Given this list of marker genes ATP2C1, CEBPB, EZR, AKAP5, GPD1L, TULP1, FLOT1, F2R, HAMP, APLN, P2RY2, GREM1, F2RL3, CARTPT, VAMP2, ATP13A2, CA2, HYAL2, ABCG1, SGK2, PTPRJ, TMED10, APOE, MPC2, IL1A, MIR223, TBC1D20, KCNB1, APELA, PDGFRB, APOA5, PLCG1, RUFY4, CASK, CDH3, PSEN1, VPS28, SCN5A, OSBPL8, CDK5, P2RY12, MS4A1, ZFAND1, VMP1, GAB2 (NCBI Gene Id 9846), MAP2, CXCL9, P2RX4, PCNT, ATP1B1, TRIM46, ITGAM, LRAT, RAB2B, CCR7, GABBR1, PLA2G10, ACTN2, LRRC52, STX18, KLRC2, STIM1, RAN, CTSS, P2RX7, KMO (kynurenine 3-monooxygenase), HOMER1, EIPR1, RAB8B, ORAI1, TACR1, FCGR2C, SYNGR3, FOXL2, SYT4, PINK1, FXYD6, COLEC10, CD38, CLIP3, VAMP7, KCNN4, CASQ1, LMAN2, RAB31, RGCC, SFRP4, P2RX5, FXYD7, RXRA, ASPH, MYB, ADCYAP1R1, IL4, PRKCD, ACSL5, GALR1, NPR1, XBP1, SLC30A3, TGFB3, OCLN, TRH, CD33, NLGN2, GRIN1, VPS4A, CD177, ATP8A2 (ATPase phospholipid transporting 8A2), PTCH1, PLA2G6, RHOQ, ICE1, NPSR1, BRAF, STAC2, SYT9, AHCYL1 (NCBI Gene Id 29039), GPR68, ZC3H12A, FGB, TMEM132A, CNTN1, RAB7A, SNCA, HLA-F, C4A, CCR1 (C-C motif chemokine receptor 1), ZNRF1, UNC13D, ACSL1, MYLK, WNT5A, ARRB1, SORL1, CAMK2A, GDNF, ATG5, GALR2, SERP1, AP2A1, TRPC3 (transient receptor potential cation channel subfamily C member 3), PRKAR1A, SIVA1, GPER1, MIR20A, TNF, ACTB, ABCG4, SFN, LRRC38, THY1, MEF2A, CREBL2, FGFR1, HCLS1, MICU3, MAPK14, RETN, MIR183, CREB3, RAB3A, PTX3, KCNJ2, SLC7A5, PPP3CC, AKT1, TOR2A, CD300LF, ABCA12, NEDD4L, ARPP19, DLL1, ATP8A1, STX4, BAD, PDCD10, XRCC4, DOC2A, BAK1, AHI1, PCM1, PLA2G4E (NCBI Gene Id 388117), PFKFB2, MLC1, ANXA2P2, RIPOR1, SDC1, APOA1, ACTN4, SLC11A1, IL1B, SYT5, MYRIP, PRAP1 (NCBI Gene Id 118471), LRRC8A, ABCA13, FCGR1A, DYNC1H1, ACE2, RBP4, NF2, HIF1A, MIR206, LPCAT3, CTDSPL2, NR0B2, SYT13, TRIAP1, AHSG, AQP1, HCAR2, FCGR1BP (NCBI Gene Id 440607), RAP1A, MIR210, IER3IP1, FXYD5, BICD1, EHD1, PRKCE, IL15RA, GHRL, OSBP, TREM2, CEP290, NADK, ZDHHC7, MYO18A, LDLRAP1, C3, SGK1, NPPB, TRPC1, AZIN1, SIRPG, ADCYAP1, CXCR3, PPARG, RAPGEF4, PPID, CASR, EEF2K, NUMA1, CREB1 (cAMP responsive element binding protein 1), SLC35D3, KHDRBS1, GPRC6A, P2RY6, APPL2, FCGR2B, TRIM28, ANKRD1, PRRT2, FRMD4A, HAP1, SMAD3, KIF20B, TPR, ZDHHC8, CRH, STK11, CFP, FABP3, CETP, CACNB3, TRPV3, C1QTNF1, AIMP1, BOK, CACNB2, GHRH, BIN1, GAS6 (growth arrest specific 6), ATF4, APBB3 (NCBI Gene Id 10307), CAPN10, TERT, PTPRC, ZP3, ITSN1, PPP3R2, CBL, FCER1G, CD81, INPP5K, ANXA2, PTPN23, CAMK1D, CADPS2, PLA2G1B, CAV3, CACNA1B, ACSL4, IFNG, PRKN, NKX3-1, SCAMP5, ZDHHC2, WNK3, CCL5, ACSL3, RACK1, ATP1B2, EHD2 (NCBI Gene Id 30846), NTSR1, FCN3, VAMP8, P2RX2, MIR17 (NCBI Gene Id 406952), LGALS3, EDEM1, SDC4, FPR2, VTN, OXT, LEP, BCR, G6PD, BTK, CNKSR3, HDAC3, HIP1R (NCBI Gene Id 9026), OAZ1, PICK1, RAB27B, CHP2, TSPO, ABCB4 (NCBI Gene Id 5244), CACNA1D, FCN1, ANKFY1, PFKM, GHRHR, KCNC1, PDPK1, TNFSF11 (NCBI Gene Id 8600), FCGR2A, EP300, MLLT6, FXYD4, ATP2C2, ITLN1, RIOK2, CLU, TNFRSF11A, DENND5B, EEPD1, TARDBP, TACR2, FUT11, C2CD5, HGS (NCBI Gene Id 9146), P2RX1, UBR5, SRI, RPH3AL, NPY2R, PLTP, AVPR1A, VEGFC, IPO5, BMP6, RUFY3, CD36, ADCY8, ANK3, CRACR2A, CXCL11 (C-X-C motif chemokine ligand 11), SNX4, SLC1A2, JUP (junction plakoglobin), RAB5A, TRPA1, LYAR, BAG3, STAP1, PRKD1, TF, ILDR1, SYT8, SCT, PPM1A, PLA2G5, JPH2, SFTPD (surfactant protein D), SLC18A3, GAL, EGF, DOCK2, AZIN2, CHP1, EDN3, SGIP1, IL13, FMR1, TMEM30B, SEC24A, LIPG (NCBI Gene Id 9388), SOD1, SIRT1, PGRMC1, CDH2, SPHK2, ADORA2A, MYOM1, FXYD3, ERFE, NKX6-1, APLNR, NTF3, TM9SF4 (transmembrane 9 superfamily member 4), FGG, MAVS, FEZ1, SLC2A2, TSG101, ADORA2B (adenosine A2b receptor), MDM2, HLA-DRB1, CALY, FXYD6P3, STXBP1, CD14, AXL (NCBI Gene Id 558), FASLG, GCK, NFE2L2, TENM1, AKT2, ADAM8, PIK3R1, EFCAB7, TUB, PSMD9, FGA, NPPA, VPS11, SMO, PRSS8, TUNAR, CHCHD10, ARRB2, SMAD4, FGR, STXBP5, BAIAP3, MCHR1 (melanin concentrating hormone receptor 1), CRYZL2P-SEC16B, COMMD1, SHH, MCU (NCBI Gene Id 90550), TCAF1, GSK3B, ZNRF2, PPIA, GPLD1, KCNIP2, RHBDD1, TRPV2, IL4R, ABAT, PRL, APP, XPO4, STC1, PTGES, TBC1D5, BORCS5, ANO6, KCNC2, RAB3GAP1, ITGB2, HYAL3, B2M, FXYD2, GLI3, DRD1, VPS35, PRELID1, BCAP31, SYT7, KLF15, SYT2, RAPGEF3 (NCBI Gene Id 27105), GH1, C1QTNF12 (NCBI Gene Id 388581), OPN3, PRP4K, CD19, PLCG2, ABCA1, TAC1, GRM6, PRR5L, OXCT1, COX17, ABCB11, DRD4, TGFB1, PPP3CA, CLEC7A, PDCD6IP, NFKB1, CEMIP, FFAR2, XCL1, ATP1B3, ARHGEF5, LRRC26, PTH, PTPN11, SPAG5, WLS, CCL4, ECT2, CD2AP, WASL, NR1H3, MBL2, CLASP1, PPARD, CLASP2, CDK5R2, CLN3, DTNBP1, LCN2, AACS, PARD6A, SCN3B, RNASEL, GCG, CHRNB2, ANXA1 (NCBI Gene Id 301), LACRT, DMAP1, CCL2, NOS1AP, CAPN3, BLK, FLNA, MTMR2, SELENOT, WFS1, ARAP1, BAX, UNC13B, MAGI2, SLC38A3, MIR1-1, NR4A3, MIR21, CALR, ABL1, CD63, PRKCI, STAM, SLC12A2, CNST (consortin, connexin sorting protein), ITGB1, ABCA7, NCBP2, FCN2, SLC6A4, TGFB2, PDGFB, LAMP1, PRKCA, STIMATE, SNAPIN, SLC30A8, WNT3A, FFAR4, HEPH, DNM1L, GRK2, SYT3, F2RL2, GIP, SOX11, AVPR1B, NMU (NCBI Gene Id 10874), ANO1, ITPR1, RAB9A, ADRA2A, FGF12, LRP1, ADAM9, ARL6IP1, CPSF6, STAC3, DAB2, IRS2, F2RL1 (F2R like trypsin receptor 1), ISL1, DGKD, PRKACA, CDK1, FHL1, APPL1, P2RY1, CD4, FXYD1, AP2B1, UCN, SEC16B, CBLL1, TLR4, STX1A, H1-1, HCRT, TRPM4, SIRT6, DHX9, SCN4B, SLC34A1, SCIN, KCNQ1, ANP32B, YWHAE, RPH3A, STX1B, CHMP2A, VPS4B, FGF21, ATP2B1, TOR1A, C1QTNF3, DLG1, CYP4F2, AKAP6, CD151, SLC51B, RBM22, INHA, RAB3B, PCSK9, OAZ2, GSK3A, F2, HFE, ABCC8, UCN3, FGF13, ANG, NIPSNAP2, IL2RB, ECRG4, BSG, CCL3, APOA2, IL15, INSR, RAB21, JAK2, CFTR, PKP2, KCNH2, RAP1GAP, SERPINE1, PLA2R1, TMEM30A, EDEM2, PPP3CB, ARF6, NEDD4 (NEDD4 E3 ubiquitin protein ligase), CEP131, ATP5IF1 (NCBI Gene Id 93974), MERTK, HSP90AA1, B3GAT3, ADORA1, TMEM97, C2CD2L, PLA2G3, SYTL4, TESC, GIPR, CD47, VSNL1, SCN2B, CLTRN, LRRK2, CXCL10, COLEC11, SYT10, RAB29, IRS1, GLUD1, CLTCL1, MIR199B, BGLAP, AVP (NCBI Gene Id 551), OR51E2, TM7SF3, AP2M1, RASL10B, NKX2-5 (NK2 homeobox 5), S100A10, CDH1, STRIT1, LRRC55, MYH10, LILRA5, NOS1, NCKAP1L, GATA2, CXCL12, BDKRB1, SOX4, SPACA3, ADIPOQ, MLXIPL, C2, CCL21 (NCBI Gene Id 6366), SORBS1, VEGFA, NR1H4, NNAT, STIM2, PPT1, GRP, PLK3, ATAD1, SCP2, TMF1, SELE, PIK3R2, INS, ABCA5, SYT1, GOLPH3L, EDNRA, TTN, RAB3D, PLA2G4A, DYNLL1, APBB1, ABCA8, OPRK1, PYCARD, SCN1B, ZNF205, CX3CL1, DRD2, TLR2, EXPH5, PRKCB, SIRT3, WNK2, LILRA2, NLGN1 (neuroligin 1), TRPM5, GSTO1, P2RX3, PHPT1, INHBA, CES1, ERGIC3, ITGA2, MSN, STAT3, RAB27A, SPP1, PPP3R1, GNA11, TRPC6, EMD, KCNE5, ANK2, SMPD3, LPAR3, DOC2B, NMB, TFR2, ERC2, HTT, SIRPA (signal regulatory protein alpha), CYBA, PON1, AMIGO1, INHBB, SIRPB1, STAC, BMP2, TMSB4X, HIP1, SMPD1, SYBU, RFX6, PDX1, SLC4A8, GPC3, RAC1, CYP19A1, OAZ3, MIF, NR1H2, CDC42, CADPS, ANXA13 (NCBI Gene Id 312), GOLPH3, ZPR1, DBI, IL2RG, STK39, AKAP7, POU4F2, CHRM3, SLC17A8, TCF7L2, NEGR1, SYK, GATA1, ZIC1, PLAA, GPR27, PGAP1, PTPRM, CD160, MIB1, RAB15, ACHE, KCNE1, PCK2, AP1G1, PLCB1, ANGPT1 (angiopoietin 1), S100A8, FFAR1, SDCBP, AZU1, IGF1, FUT10, CAV1, ALOX12B (arachidonate 12-lipoxygenase, 12R type), ABCA3, CHRM1, ATPSCKMT (NCBI Gene Id 134145), CAMK1, C4B, GPR158, SYT11, GPS2, CYP4A11, CCL19, SNF8, NRDE2, SLC26A6 (solute carrier family 26 member 6), FGF19, RDX, ATP2A1, KIF5B, EDN1, here is a description of the gene set: species: Homo sapiens Human Gene Set: GOBP_POSITIVE_REGULATION_OF_TRANSPORT Any process that activates or increases the frequency, rate or extent of the directed movement of substances (such as macromolecules, small molecules, ions) into, out of or within a cell, or between cells, by means of some agent such as a transporter or pore.